The following is a description of a gene set: species: Mus musculus A process that is carried out at the cellular level which results in the assembly, arrangement of constituent parts, or disassembly of a pseudopodium, a temporary protrusion or retractile process of a cell, associated with cellular movement. Mouse Gene Set: GOBP_PSEUDOPODIUM_ORGANIZATION, and this is the list of marker genes: Cdc42ep1, Kit, F2rl1, Cdc42ep5, Rab25, Septin7, Klhl41, Ccl21a, Cdc42ep2, Srgap2, Ccl21f, Ccl21d, Apc, Ccl21e, Gm14137, Ccl5, Cdc42ep4, Cdc42ep3, Cdc42, Ccl21b (NCBI Gene Id 20298)